Given this list of marker genes NT5DC1, ATAD1, RIC1 (RIC1 homolog, RAB6A GEF complex partner 1), CBR4, TGFBR1, RPL35, TMEM19, LERFS, ZDHHC13, CASP8AP2, ZNF516, NMRK1, TBC1D4, IGF1R, SNAPC1 (NCBI Gene Id 6617), GSDME, HEMGN, STON2, IFI16, FOXO1, PIK3R1, MRPL50, SNHG29, PHF3, KRT13, PPP6C (NCBI Gene Id 96749), TPD52L1, DAB2IP, FABP5, ATP6V1G1, RXRA, TSPYL1, BBX, PGAP4, FDXACB1 (NCBI Gene Id 91893), STX17, VPS13A, TM2D2, BDH2, CARNMT1, FBP1, DGLUCY, PLD1, WDR41, GNAI1, RPL27A, ESD, TMOD1, GSTA4, MAT2B, ANP32B, HOXA3, RBM18, RBM12, CAST, BEX2, BBS1, GUK1, GNG10, ERP44, FAHD2A, SNAPC3, TOR1A, ZNF513, GALNT1, TMEM268, ABITRAM, ANKRD16, CPA4, RPL15, MAP3K7, BRD3, CDIP1, CIBAR1, JTB (jumping translocation breakpoint), PTGR3, INIP, FOXM1, CASP1, ASTN2, MEIS3P1, TMX4, PTPRN2, STX3, FUBP3, GSTO1, SERPINB5, PTPDC1, RPL10A, MOB3C, TCEAL1, APTX, EIF3L, PRKCQ, GNPDA2, PNRC1, PBX3, MLLT3, RARA, RPL6, MITF, PSMD5, ZCWPW1, LDLRAD4, RAB14, NLGN4X, TMEM245, SKAP2, TUBG2, FBXW2 (NCBI Gene Id 26190), ZNF462, INTS10, RPL7A, PYGL, ZMAT1, CORO2A, MED7, PRXL2A, SALL2, XPA, here is a description of the gene set: from publication Lindgren D, Liedberg F, Andersson A, Chebil G, Gudjonsson S, Borg A, Månsson W, Fioretos T, Höglund M (PMID 16532037) Human Gene Set: LINDGREN_BLADDER_CANCER_CLUSTER_1_UP species: Homo sapiens We used gene expression profiling, mutation analyses of FGFR3 and TP53, and LOH analyses of chromosome 9 and the TP53 region on chromosome arm 17p, to molecularly characterize 75 Ta and T1 bladder carcinomas. We identified four major cellular processes related to cell cycle, protein synthesis, immune response, and extra cellular components that contribute to the expressional heterogeneity of early-stage urothelial cell carcinoma (UCC). Activating FGFR3 mutations were found at the highest frequency in G1 tumors (80%), and showed a strong correlation with FGFR3 expression. In contrast, G3 tumors displayed mutations in less than 10% of the cases and a low level of FGFR3 expression. Even though LOH on chromosome 9 was not associated with any specific expression pattern, our data indicate that loss of chromosome 9 is associated with tumor development rather than initiation. The combined analyses suggest the existence of two types of UCC tumors, one which is characterized by FGFR3 mutation or expression, high expression of protein synthesis genes, and low expression of cell cycle genes. Furthermore, the presented data underscore FGFR3 receptor involvement in urothelial cell transformation as the presence of FGFR3 mutations has a major impact on the global gene expression profile of bladder carcinomas. Up-regulated genes whose expression profile is specific to Custer I of urothelial cell carcinoma (UCC) tumors.